Given this list of marker genes PRKAB2, IL13, NRDC, STK11, IL4R, ZNF516, TRPM2, BMAL1, SLC27A1, CMKLR1, RBPJ, ALMS1, ATF4, GPX1, FABP4, ADRB3, ADIPOR1, GNAS, KSR2, FH, ABHD6 (abhydrolase domain containing 6, acylglycerol lipase), ADIPOQ, PTGER3, SFXN5, SMARCA4, FLCN, HTR2A, HCRT, PPARGC1A, ELOVL3, ADAMTS5, TLE3, GJA1, CCR2, GATM, TNFSF11, JAK2, VEGFA, TLR4, NR1D1, LEPR, ACADVL, EPAS1, ACOT11, PRKAB1, PTGS2, WNT10B, ELOVL6, FFAR4 (NCBI Gene Id 353126), ADORA1, NAPEPLD, SLN, PTGES, IGF2BP2, ADRB2, ALPL, LPIN1, CD36, DOCK7, LETMD1, FOXO1 (forkhead box O1), PEMT, DECR1, APPL2, NR1H3, LAMA4, FOXC2, ALDH1A1, QKI, TRPV2, CIDEA, APC, PLAC8, MC3R, APLN, IGF1R, IL1A, DRD2, NTSR1, THRA, PRLR, OMA1, PPARGC1B, ACOT13 (NCBI Gene Id 55856), HOXC10 (homeobox C10), PWWP2B, RHEB, LGR4, NMU, TNF, FABP5, ADAM17 (NCBI Gene Id 6868), GPR3, IL18R1, TFE3, ACHE, EDN2, NR1H2, TNFRSF11A, CPT2, TRPM8, SQSTM1, GHRL, IL4, EHMT1, PRDM16, IL15, DYNC1H1, ADRB1, PCTP, LCN2, ACVR2B, ID1 (inhibitor of DNA binding 1), DIO2, PHOX2B, PTH2R, ADIPOR2, IRF4, ACADL, OXT (NCBI Gene Id 5020), KDM6B, EGR1, LEP, OXTR, ARRDC3, CEBPB, PGAM5 (PGAM family member 5, mitochondrial serine/threonine protein phosphatase), HADH, GADD45G (NCBI Gene Id 23575), STAT3, NPR3, SCD, MFN2, ESRRG, EDNRB, NOVA2, STAT6, KDM3A, SIRT6, DBH, MFAP2, IL1B, IP6K1, PER2, PLCL1, SLC25A44, DDIT3, CNOT3, UCP1, GRB10, PLCL2, HDAC3 (NCBI Gene Id 8841), CLSTN3, IL18, OGT, CXCR4 (NCBI Gene Id 93405), BSCL2, DRD1, FTO, MAP2K6, CAV1, FGF21, TRPV1, ADCYAP1, SYK, PDGFC, KDM1A, HSF1, ACSL1, LNPEP, NOD2, ZNF423 (zinc finger protein 423), ACTN3, NOX3, UCP2, EBF2, NOVA1, ABAT, RB1 (RB transcriptional corepressor 1), G0S2 (G0/G1 switch 2), NOTCH1, ZBTB7B, YBX2, TSHR, here is a description of the gene set: A homeostatic process in which an organism modulates its internal body temperature. Human Gene Set: GOBP_TEMPERATURE_HOMEOSTASIS studied in species Homo sapiens